Given this list of marker genes FBH1, ATRX, RAD54L (RAD54 like), ERCC6L, RAD54B, here is a description of the gene set: Human Gene Set: GOMF_DNA_TRANSLOCASE_ACTIVITY Generation of movement along a single- or double-stranded DNA molecule, driven by ATP hydrolysis. species: Homo sapiens